The following is a description of a gene set: species: Mus musculus Mouse Gene Set: MIR_677_3P from publication Chen Y, Wang X (PMID 31504780) Genes predicted to be targets of miRBase v22 microRNA mmu_miR_677_3p in miRDB v6.0 with MirTarget v4 prediction scores > 80 (high confidence targets)., and this is the list of marker genes: Evx1, Gnal, Podn, Prickle2, Macf1, Map4k4, Chrd, Calhm4, Rpp40, Trappc8, Foxa2, Pdpk1, Arid1b, Bbx, Baiap2l1, Rap2a, Gria1, Tanc2, Nlrp4a (NLR family, pyrin domain containing 4A), Cep85, Spry4, Tsg101, Top2b, Cdip1, Fubp1, Ntrk2, Tef, Adcy1, Cpeb2, Krtap3-1, Susd6, Rpl37a, Glis3, Simc1, Sgpp2, Csrnp3, Rsbn1, Fkbp1a, Pwwp3b, Aak1, Slc9a6, Snx17, Csnk1d, Sgpl1, Cyp4a14, Dok4, Cdkn2aip, Ncdn, Ryk, Lonrf1, Cenpu, Ptprk, Wasf1 (NCBI Gene Id 83767), Rest, Stpg3, Aven (apoptosis, caspase activation inhibitor), Sorbs1, Nhsl2 (NCBI Gene Id 68850), Timp4, Ptprj, Gria2, Oaz2, Dync1li2, Gja6, Pcsk5, Spock1, Zfp646, Aip, Ggcx, Sbno1, Scn4b, Far2, Car10, Gabpa, Lrrc8e, Nfat5, Adcy7 (NCBI Gene Id 11513), Xpo1, Trmt2a, Fam91a1, Golm1